The following is a description of a gene set: Mouse Gene Set: GOBP_UDP_BIOSYNTHETIC_PROCESS The chemical reactions and pathways resulting in the formation of UDP, uridine (5'-)diphosphate. species: Mus musculus, and this is the list of marker genes: Cad, Dhodh, Cmpk1, Umps, Ak9